Given this list of marker genes DENND6A, DENND4A, RAB35, DENND4B, YWHAE, TRAPPC1, DENND6B, GDI1, RAB3GAP2, TRAPPC11 (NCBI Gene Id 60684), DENND2A, RIN2, RAB3IL1, TRAPPC2, CHML, RIN1, RAB27A, CCZ1B, RAB31, RAB14, DENND1B, RAB9B, DENND4C, RAB10, RABGEF1, TRAPPC2L, TRAPPC9, MON1B, TRAPPC4, RAB1A, RAB8A, RAB6A, MON1A, RAB38, TRAPPC13, DENND1C, RAB32, RAB5A, TRAPPC6B, AKT1, TRAPPC6A, TRAPPC8, DENND2D, ULK1, RAB6B, RAB1B, DENND2C, HPS4, DENND1A, RAB5B, CHM, RAB39B, RAB21, GAPVD1 (GTPase activating protein and VPS9 domains 1), ALS2, RGP1, RIC1, ALS2CL, RAB8B, HPS1, RAB39A, RAB3IP, TRAPPC3, RAB7B, RAB12, RAB27B, CCZ1 (NCBI Gene Id 51622), RAB5C, DENND5B, DENND2B, RAB7A, RAB9A, AKT2, ANKRD27, MADD, RAB13, RINL, TRAPPC5, AKT3, RAB18, DENND3, TRAPPC12, SBF2, RAB3A, RIN3, SBF1, TRAPPC10, GDI2, DENND5A, RAB3GAP1, here is a description of the gene set: part of: Rab regulation of trafficking studied in species Homo sapiens Human cells have more than 60 RAB proteins that are key regulators of intracellular membrane trafficking. These small GTPases contribute to trafficking specificity by localizing to the membranes of different organelles and interacting with effectors such as sorting adaptors, tethering factors, kinases, phosphatases and tubular-vesicular cargo. <br><br>RAB localization depends on a number of factors including C-terminal prenylation, the sequence of upstream hypervariable regions and what nucleotide is bound, as well as interaction with RAB-interacting proteins. More recently, the activity of RAB GEFs has also been implicated in regulating the localization of RAB proteins (Blumer et al, 2103; Schoebel et al, 2009; Cabrera and Ungermann, 2013; reviewed in Barr, 2013; Zhen and Stenmark, 2015)<br><br>In the active, GTP-bound form, RAB proteins are membrane-associated, while in the inactive GDP-bound form, RABs are extracted from the target membrane and exist in a soluble form in complex with GDP dissociation inhibitors (GDIs). Conversion between the inactive and active form relies on the activities of RAB guanine nucleotide exchange factors (GEFs) and GTPase activating proteins (GAPs).<br><br>Newly synthesized RABs are bound to a RAB escort protein, CHM (also known as REP1) or CHML (REP2). CHM/REP proteins are the substrate-binding component of the trimeric RAB geranylgeranyltransferase enzyme (GGTaseII) along with the two catalytic subunits RABGGTA and RABGGTB. REP proteins recruit the unmodified RAB in its GDP-bound state to the GGTase for sequential geranylgeranylation at one or two C-terminal cysteine residues. After geranylation, CHM/REP proteins remain in complex with the geranylated RAB and escort it to its target membrane, where RAB activity is regulated by GAPs, GEFs, GDIs and membrane-bound GDI displacement factors (GDFs).<br><br>Unlike the RAB GAPS, which (to date) all contain a shared TBC domain, RAB GEFs are structurally diverse and range from monomeric to multisubunit complexes. While many GEFs contain one of three conserved GEF domains identified to date - the DENN (differentially expressed in normal and neoplastic cell) domain, the VPS9 domain and the SEC2 domain- other GEFs lack a conserved domain. Based on sequence conservation and subunit organization, GEFs can be grouped into 6 general classes: the DENND-containing GEFs, the VPS9-containing GEFs (both monomeric), the SEC2-containing GEFs (homodimeric), heterodimeric GEF complexes such as RIC1:RGP1, the multisubunit TRAPPC GEF, and others. GEFs for many RABs have still not been identified, however. Reactome Pathway: RAB GEFs exchange GTP for GDP on RABs